Given this list of marker genes H2BC13, KLRG1, BABAM1, IRAK2, PRKD3, ELF4, CST3, STIP1, PPP2CB, MDGA2, PRICKLE3, AMDHD2, MATN2, SIRT2, RRM2, ABCC2, ATP6V1E1, SWAP70, TUFT1, GSE1, PDZD8, GBP7 (guanylate binding protein 7), SEPHS2, PRKAG1, PSMD13, MED11, ACAA2, MDFIC, B4GALT1, CD86, NOMO1, CAPG, SLC16A6, KLRC1, TMEM129, ZNF697, FLT3LG, IL12RB2, BANK1, TBL2, CCR9, NABP1, PPP1R12A, S100A4, PIK3R5, BTG3, GBP4, DDR1, ACOXL, C15orf39, TIPRL, ANXA6, TSHZ1, EIF3C, RNPEP, PCDHB13, MDM2, CELF5, METRNL, CHD7, GEM, SNX9, ANXA1, CCHCR1, CORO2A, ATP1A2, STT3B, ENPP1, SMC5, PYCARD, ZDHHC21, LFNG, ECT2, BAZ1A, PCYT1A, CKAP2L, ALOX15B, ENKD1, YBX3, IL15RA, DCBLD2, NT5C3B, HDAC3, AOPEP, KBTBD2, MED7, THBS2, SYTL2, NUP54 (nucleoporin 54), TMEM128, DPH1, CBX4, HOPX, SAMHD1, WDR44, RAP2A, RSPH6A, SDHB, SGO1, UST, KCNK6, HS3ST3B1, LMAN1, RASGRP2, NHSL3 (NHS like 3), DKKL1, ANAPC11, TBX21, DCAF15, ZC3H8, ING1, PADI2, DSCC1, SAPCD2, DNAJC15, PRKAR2A, PAK6, DIPK1A, GUCD1, ZEB2, CBLN4, UCHL5, PDSS1 (NCBI Gene Id 23590), MYADM, PRR5L, GNA15, MKI67, AVEN, HELB, OSBPL3, CYP2S1, CMTM6 (CKLF like MARVEL transmembrane domain containing 6), TMEM41B, IL12RB1, SIKE1, BORA, ARL5A, TTLL3, ALCAM, ILDR1, MMACHC, CYTH2, ID2, LGALS1, EEF1E1, SNHG3, KRTAP17-1 (NCBI Gene Id 83902), CREBZF, GPAT3, GAS2L3, ITGAX, ZBTB38, TMEM14C, BIK, RNGTT, HAAO, TNS2, CLDND2 (NCBI Gene Id 125875), GOLT1B, TUBGCP2, DENND2C, PRKAR2B, SDF2L1, BANF1, POLE3, CDH9, AIRN, ITGA2, RBPJ, RAP1GAP2, SP3, ZNF654, DPYS, GNAI2, ZDHHC15, WRNIP1, COX5A, FABP5, DYNLRB2, NUCB1 (nucleobindin 1), MTFMT, COPS3, AFG2A, PLP2, PARPBP, SANBR, PPP1R14C, AK3, GEMIN2, BRCA1, NCCRP1, LRRC8A, PPP1R18, MYO1F, STRN, CCNF, VAX2, CHADL, TMBIM1, CEP120, here is a description of the gene set: Human Gene Set: GSE36078_WT_VS_IL1R_KO_LUNG_DC_AFTER_AD5_T425A_HEXON_INF_UP species: Homo sapiens Genes up-regulated in Lung dendritic cell from Ad5 T424A hexon infection wildtype mice versus Lung dendritic cell from Ad5 T424A hexon inf IL-1R mice. from publication Doronin K, Flatt JW, Di Paolo NC, Khare R, Kalyuzhniy O, Acchione M, Sumida JP, Ohto U, Shimizu T, Akashi-Takamura S, Miyake K, MacDonald JW, Bammler TK, Beyer RP, Farin FM, Stewart PL, Shayakhmetov DM (PMID 23019612) Discrimination between self vs. non-self and adequate response to infection and tissue damage are fundamental functions of the immune system. The rapid and global spread of known and emerging viruses is a testament that the timely detection of viral pathogens that reproduce within host cells, presents a formidable challenge to the immune system. To gain access to a proper reproductive niche, many pathogens travel via the host vasculature and therefore become exposed to humoral factors of the innate immune system. Although a cascade of coagulation factors plays a fundamental role in host defense for “living fossils” such as horseshoe crabs (Xiphosurida spp), the role of the coagulation system in activation of innate responses to pathogens in higher organisms remains unclear. When human type C adenovirus (HAdv) enters the circulation, 240 copies of coagulation factor X (FX) bind to the virus particle with picomolar affinity. Here, using molecular dynamics flexible fitting (MDFF) and high resolution cryo-electron microscopy (cryo-EM), we defined the interface between the HAdv5 hexon protein and FX at pseudo-atomic level. Based on this structural data, we introduced a single amino acid substitution, T424A, in the hexon that completely abrogated FX interaction with the virus. In vivo genome-wide transcriptional profiling revealed that FX-binding-ablated virus failed to activate a distinct network of the early response genes, whose expression depends on transcription factor NFKB1. Deconvolution of the signaling network responsible for early gene activation showed that the FX-HAdv complex triggers MyD88/TRIF/TRAF6 signaling upon activation of toll-like receptor 4 (TLR4) that serves as a principal sensor of FX-virus complex in vivo. Our study implicates host factor “decoration” of the virus as a mechanism to trigger innate immune sensor that respond to a misplacement of coagulation FX from the blood into intracellular macrophage compartments upon virus entry into the cell. Our results further the mounting evidence of evolutionary conservation between the coagulation system and innate immunity.